Given this list of marker genes KDF1, MAP3K14, ZZZ3, TBX19, UBE2H, INCA1, FGFBP1, FHIT, TTC28, HS1BP3, TRAF4, EMB, PLEKHA1, PHLDB1, CD320, NSMCE1, IFT80, FZD7, KDM3A, PIK3C2A, ZNF281, ITGAE, CCND2, TSPAN14, STMN4, F2RL1, SIMC1, ELP1, DNAJC27, IST1, FAP, RETREG1, KBTBD2, RPS3A, ENC1, KCNK2, BACH2 (BTB domain and CNC homolog 2), PLOD1, SPATA6, CDIP1, CAP2, CLOCK, ABL1, YRDC, PPTC7, CTDSP2, RPS16, AFF1, CRY2, USP36, UTP25, RFLNB, RHOBTB2, IL21R, ACVR2A, BLTP1, AADAT, PIAS1, CBFA2T2, PDZK1, PPP1R3F, NSG2, OAS2, SH3BGRL2, DZIP1, SH3BP5, NCOA3, HEATR1, STAU1, EFEMP2, RNF167, FAM8A1, ADH1C, TACC2, HSD17B11, RASA2, SFSWAP, HS6ST1, ITPKB, ACTN1, SMAD7, TRIM13, ELOVL6, VPS37B, KLK6 (NCBI Gene Id 5653), SCARB2, ZFP90, SIGLEC1, TLR1, COX7A2L, SMAD4 (SMAD family member 4), DNAH8, RNF103, TRAT1, RNF185, TEC, TLE4, KCNQ1, CIC, HCN3, PDK1, ATP8A2, WDR74, RGS10, AMACR, RAMP3, ZFP1, EEF1G, ZNF474, RAB3IP, GPR83, FRAT2, RPL14, ZFYVE26, SORCS2, FNBP4, PNRC1, IGFBP4, TUSC2, TGIF1, ARMCX4, ITGA6, NOC4L, MYB, NRG4, DDX60, CFI, MEPCE, CBX2, CACNA2D2 (NCBI Gene Id 9254), ETS2, MDN1, MSANTD2, CCR7, DUSP10, RAI1, TDRP, HBP1, SARAF, TSPAN1, CHKB, CALCRL (NCBI Gene Id 10203), NR1D2, KRTAP19-1, NEDD4L, CLP1 (NCBI Gene Id 10978), CHRNB1, RBM5, TMEM245, PATJ, GSTK1, TTR, IER5L, IP6K1, STX1A, SMAD1, TFF2, SELL, CRLF3, APPL2, ADGRA2, COL2A1, DIP2B, DPH5, TANC1 (tetratricopeptide repeat, ankyrin repeat and coiled-coil containing 1), DPF3, DSTYK, IKBKB, TRMT1, ASB13 (ankyrin repeat and SOCS box containing 13), KPNA1, TTF1 (NCBI Gene Id 7270), RNF146, ZNF593, MRTFA, PITPNM2, SPRED2, PTK2, NOP53, ZMYND11, CAMK2D, ZBTB20, ULK1, DGAT2, TSR1, RPL3, BPHL, IGHMBP2, EML5, AACS, SMC4, PHAF1, TIMP2, MSGN1, SHF, CD2AP, C19orf73, CUEDC1, here is a description of the gene set: Human Gene Set: GSE33162_UNTREATED_VS_4H_LPS_STIM_HDAC3_HET_MACROPHAGE_UP Genes up-regulated in macrophages with heterozygous knockout of HDAC3: untreated versus LPS. Pan-Hdac inhibitors (HDACi) are endowed with a potent anti-inflammatory activity, but the relative role of each of the eleven Hdac proteins sensitive to HDACi to the inflammatory gene expression program is unknown. Using an integrated genomic approach we found that Hdac3-deficient macrophages are unable to activate almost half of the inflammatory gene expression program when stimulated with lipopolysaccharide (LPS). A large part of the activation defect is due to loss of basal and LPS-inducible expression of IFNb, which in basal cells maintains Stat1 protein levels, and after stimulation acts in an autocrine/paracrine manner to promote a secondary wave of Stat1-dependent gene expression. We show that loss of Hdac3-mediated repression of nuclear receptors leads to hyperacetylation of thousands of genomic sites and associated gene derepression. The upregulation of the constitutively expressed prostaglandin endoperoxide synthase, Ptgs1 (Cox-1), has a causative role in the phenotype, since its chemical inhibition reverts the Ifnb activation defect. These data may have relevance for the use of selective Hdac inhibitors as anti-inflammatory agents. studied in species Homo sapiens from publication Chen X, Barozzi I, Termanini A, Prosperini E, Recchiuti A, Dalli J, Mietton F, Matteoli G, Hiebert S, Natoli G (PMID 22802645)